The following is a description of a gene set: studied in species Mus musculus Mouse Gene Set: GOCC_MICROFIBRIL Extracellular matrix components occurring independently or along with elastin. Thought to have force-bearing functions in tendon. In addition to fibrillins, microfibrils may contain other associated proteins., and this is the list of marker genes: Ltbp4, Mfap4, Mfap5, Efemp2, Fbn1, Thsd4, Mfap2, Mfap1a, Fbn2, Adamtsl5, Ltbp1, Adamts10, Mfap1b